The following is a description of a gene set: Catalysis of the hydrolysis of ester linkages within ribonucleic acid by creating internal breaks. species: Homo sapiens Human Gene Set: GOMF_RNA_ENDONUCLEASE_ACTIVITY, and this is the list of marker genes: POP4, YBEY, RIDA, ANKZF1, FEN1, RNASEL, RNASEH1, MBLAC1, RPP21, RPP25 (ribonuclease P and MRP subunit p25), ANG, NUDT16, PIWIL3, NOB1, RNASE8, DICER1, SLFN13, RNASET2, RNASE2, INTS11, ELAC2, PRORP, ZC3H12A, TMBIM6, POP5, SMG6, AGO1, ZC3H12D, NUDT12, MRPL44, RNASEK, ABCE1, TSEN34 (tRNA splicing endonuclease subunit 34), APEX1, RPP40, PLD6, NUDT16L1, LACTB2, KHNYN, ZC3H12B, ENDOU, DROSHA, ENDOG, ELAC1, AGO2, PIWIL1, AGO3, ERN1, TSNAX, ERN2, RCL1, POP1, DBR1, PIWIL4, TSEN2, RPP38, RNASE1, SLFN14, EXOG, RNASEH2A, POP7, ENDOV, AGO4, PIWIL2, PPP1R8, RPPH1, RPP14, SND1, CWF19L1, ZC3H12C, NYNRIN, RPP30, EXO1, RNASE4, CPSF3